Given this list of marker genes Hnrnpa2b1, Mir207, Xpnpep3, Hsph1, Hspd1, Phf14, Btnl5-ps, Dnaja1, Hsp90aa1, Trim50, Rbsn, Mrps18c, Gm15389, Gm10069, Rnf215, Cbx3, Uspl1, Luzp4, Col3a1, Mir6350, Stard10, Setx, Actmap, Czib, St13, Zfp414, Zfp532, Hspe1, Fkbp4, Gnptg, Stip1, Mm2pr, Hsp90ab1, Ndufa4, Csn1s2a, Notch1, Aldh1a2, Homez, Acot7, Trrap, Ccdc117, Gm7048, Rsrp1, Hspa8, Cse1l, here is a description of the gene set: species: Mus musculus Genes containing one or more binding sites for (Hsf2) in their promoter regions (TSS -1000,+100 bp) as identified by GTRD version 20.06 ChIP-seq harmonization. from publication Yevshin I, Sharipov R, Kolmykov S, Kondrakhin Y, Kolpakov F (PMID 30445619) Mouse Gene Set: HSF2_TARGET_GENES